The following is a description of a gene set: Mouse Gene Set: GOBP_POSITIVE_REGULATION_OF_TOLERANCE_INDUCTION species: Mus musculus Any process that activates or increases the frequency, rate, or extent of tolerance induction., and this is the list of marker genes: Nr5a2, Irak3, Cblb, Itch, Tgfbr2, Lilrb4a, Lilrb4b, H2-M3, Cd3e, Ido1, Foxp3, Foxj1